Given this list of marker genes HBA1, EPCAM (epithelial cell adhesion molecule), LMNA, CNRIP1, CA1, HMBS, NFIA (NCBI Gene Id 4774), APOC1, S100A6, HBA2, CASP3, REXO2, TMEM14C, RHAG, DENND10, HES6, KCNH2, KLF1, HBG2, FBXO7, STRADB (NCBI Gene Id 66009), HBG1, GYPB, SMIM10, TFR2, CAST, HAGH, TFRC, GATA1, SYNGR1, BLVRB, ANK1, MYC, CD36, AHSP, PRDX2, UROD (NCBI Gene Id 7389), CSF2RB, FECH, HBB, HBQ1, UBAC1, FAM178B, SLC25A37, MPC2, APOE, FCGRT, HBD, CA2, PLIN2, here is a description of the gene set: Human Gene Set: GAVISH_3CA_MALIGNANT_METAPROGRAM_33_RBCS Genes upregulated in subsets of cells of a given type within various tumors In this study, an extensive analysis was conducted to define meta-programs (MPs) capturing intra-tumor heterogeneity across a spectrum of tumor types. The approach utilized non-negative matrix factorization (NMF) to analyze each cell type separately within individual tumor samples. This involved the analysis of malignant cells, macrophages, fibroblasts, endothelial cells, epithelial cells, T-cells, and B-cells. NMF was executed with varying parameter values (K=4, 5, 6, 7, 8, 9), thereby generating 39 programs for each cell type per sample. Each NMF program was summarized by the top genes based on NMF coefficients.\nRobust MPs were then delineated for each cell type using a set of stringent criteria, including recurrence within the same tumor, similarity to programs in other tumors, and non-redundancy within a tumor. Subsequently, these robust NMF programs were clustered (per cell type) based on Jaccard similarity, leading to the identification of MPs associated with each cell type.\nTo enhance the quality of the MPs, a refinement steps were undertaken, involving the removal of MPs suspected of reflecting low-quality data (with an overrepresentation of ribosomal proteins or mitochondrial-encoded genes), single-study inclusion, or similarity to miss-annotated cell types. from publication Gavish A, Tyler M, Greenwald AC, Hoefflin R, Simkin D, Tschernichovsky R, Galili Darnell N, Somech E, Barbolin C, Antman T, Kovarsky D, Barrett T, Gonzalez Castro LN, Halder D, Chanoch-Myers R, Laffy J, Mints M, Wider A, Tal R, Spitzer A, Hara T, Raitses-Gurevich M, Stossel C, Golan T, Tirosh A, Suvà ML, Puram SV, Tirosh I (PMID 37258682) species: Homo sapiens